Given this list of marker genes Ywhaz, Iqck, Nup50, Abca9, Luc7l2, Ube2d1, Ccl20, Diablo, Apobec3, Fam91a1, Abhd17b, Fkrp, Tcaf1, Xpr1, Sytl4, Orc2, Hook3, Zfp326, Gstm5, Slain2, Ranbp9, BC035044, Dscaml1, Kpna6, Dnaja1, Cpm, Rab9b, Stx2, Lrrc19, Myo15a, 4930579G24Rik, Mfsd4b5, Oprl1, Dpf2, Shank2, Pcdh10, Pes1, Pogk, Gm1110, Vmn1r66, Fbxl17, Chrna6, Rora, Cyb5r2, Grik1 (NCBI Gene Id 28183), Dsg1b, Hbq1b, Acsm2, Mmp24 (matrix metallopeptidase 24), Fign, Clint1, Prox1, Cdh13, Elmod1, Zbtb41, Tpgs2, Ranbp6, E2f3, Kcnma1, here is a description of the gene set: species: Mus musculus from publication Chen Y, Wang X (PMID 31504780) Genes predicted to be targets of miRBase v22 microRNA mmu_miR_7220_5p in miRDB v6.0 with MirTarget v4 prediction scores > 80 (high confidence targets). Mouse Gene Set: MIR_7220_5P